The following is a description of a gene set: An abnormality of the helix. The helix is the outer rim of the ear that extends from the insertion of the ear on the scalp (root) to the termination of the cartilage at the earlobe. studied in species Homo sapiens Human Gene Set: HP_ABNORMAL_HELIX_MORPHOLOGY Abnormal helix morphology, and this is the list of marker genes: CSNK2A1 (casein kinase 2 alpha 1), ASXL2, SLC6A8, RREB1, FRAS1, NR2F1, EDEM3, SEC24C, KRAS, SPOP, SPRED2, DYRK1A, FOXP2, BCL11A, ASPRV1, PIGY, TGFB3, FGFR3, PLCB4, PPP2R3C, ABCA12, DHX30, PIGO, GNAI3, IGF2, TBX1, MAP1B, CSPP1, SUPT16H, NFIA, NAA10, ALOX12B, KCNQ1OT1, DSP, NARS1, H4C5, GPC4, BRAF, AMER1, CREBBP, BHLHA9, CPT2 (carnitine palmitoyltransferase 2), FGFR2, PEX5, RTTN, RRAS2, TMEM94, EP300, XYLT2, SOS2, PYCR2, COL2A1, HOXA2, PBX1, FBN2, EBP, PEX2, TFAP2A, CASP2, ALOXE3, LZTR1, PIGS, FBN1, CDH2, HS2ST1, RIT1, ZFX, TRIO, SMS, PGM2L1 (NCBI Gene Id 283209), NSD2 (nuclear receptor binding SET domain protein 2, NCBI Gene Id 7468), SPECC1L, GP1BB, HSPG2, RRAS, RAF1, TCF4, CDKN1C, GNB1, TCTN3, PIGL, SOS1, DOCK7, SLC25A12, FREM1, AASS, SIN3A, COMT, SLC26A2, RASA2, NIPAL4, NIPBL, LIPN, BMP2, GPC3, MRAS, FOXP1, DIS3L2, TGM1, ERF, PTPN11, FZD2, NFIX, POGZ, RB1, NDP, FANCB, KCNQ1, AHDC1, GDF11, NRAS, KDM6A, LMNA, ZMIZ1, SCNM1, MAP2K1, PPP1CB, CYP4F22, BCOR, SEMA3E, RPS23, PIGN, JUP, MAPRE2, PGAP3, PIGV, KMT2D, KCTD1, STEEP1, RECQL4, LONP1, PYCR1, SETBP1, TCF3, CLIC2, TWIST1, ZNF462 (NCBI Gene Id 84452), ZMYND11, PIGB, DDX6, SLC16A2, TUBB, PAH, TBX2, ACBD5, MED12, CBL, CHUK, SCARF2, DDX3X, CPOX, FN1, SALL1, RNU4-2, DACT1 (NCBI Gene Id 51339), KANSL1, ZMPSTE24, SLC32A1, EFTUD2, TAF1, PGAP2, UFD1, JMJD1C, PIGW, AGO2, MAP2K2, SULT2B1, SDR9C7, ADAMTSL2, PEX1, PIGA, EDN1, AMMECR1, VPS51, NF1, EBF3, CDK13, ARVCF, AFF2, KIAA0586, TASP1, SMC1A, CTCF, HIRA, AFF4, CHD7, BICRA, ACTB